The following is a description of a gene set: Human Gene Set: HP_ABNORMAL_CENTRAL_SENSORY_FUNCTION An abnormality of sensation related to CNS function. Assuming the primary sensory modalities are intact and the patient is alert and cooperative, the presence of an abnormality of sensory function may indicate a lesion of a parietal cortex, the thalamocortical projections to the parietal cortex, or the spinal cord. Abnormal central sensory function species: Homo sapiens, and this is the list of marker genes: SMARCE1, SMARCB1, PIK3CA, AKT1, TRAF7, PDGFB, SUFU, TERT, NF2, SMO, ATP6AP2, PRNP, BAP1